Given this list of marker genes Fignl2, Notum, Spast, Hspa1a, Katna1, Nsf, Fign, Hspa1b, Clpb (NCBI Gene Id 404563), Hspa8, Katnal1, Fignl1, Katnal2, here is a description of the gene set: A molecular function that involves direct binding to one of the subunits of a protein-containing complex and promoting the dissociation of one or many subunits. This often happens by changing the conformation of the protein being bound, which decreases its affinity for the rest of the complex. species: Mus musculus Mouse Gene Set: GOMF_PROTEIN_CONTAINING_COMPLEX_DESTABILIZING_ACTIVITY